The following is a description of a gene set: from publication Tabula Muris Consortium (PMID 32669714) studied in species Mus musculus Mouse Gene Set: TABULA_MURIS_SENIS_LUNG_CD8_POSITIVE_ALPHA_BETA_T_CELL_AGEING, and this is the list of marker genes: Vim, H2-D1, Ccl5, Gzmm, Ahnak, Eomes, Cxcr3, Serpina3g, Mycbp2, Cd8b1, Scgb1a1, Crip1, Nab1, Rgs1, H2az1, Ms4a4b, Nkg7, Ms4a4c, Fasl, Gpr183 (NCBI Gene Id 321019), S100a6, Ctla2a, Lpin1, H2-K1, Id2, Gzmk, Calm1, Cst7, Plek, Ccnd2, Klrk1, Lgals1, Fcgrt